Given this list of marker genes SKIDA1, CLDN10, ZDHHC5, LUC7L3, OPTC, DGKH, RERE, KCNC1, ITGBL1, DTX2, LEAP2, ANP32D, LEMD1, DSG1, LAMTOR3, KCNK3, H2AZ1, PDZD2, IKZF4, KRT20, CCM2L, LOX, CDKN1B, PDHA2, EPHA2, AMY2A, PRKAG1, INTS4P1, HAUS3, CNOT2, KLF3-AS1 (NCBI Gene Id 79667), FRY, TMEM145, LTBP3, CPEB4, ACVR2A, BCL9, JPH1, WNT8B, PDGFRA, DLX1, GRM2, GPM6B, RGN, CCDC33, VGF, FOXA1 (NCBI Gene Id 3169), TSHZ2, GAL3ST3, ZNF436, CACNA2D2, CAMLG, NFIL3, COPB1, RAP2B, TOP6BL, NOTCH1, PGM2L1, RRN3P1, TCN2, QRICH1, BDNF, CEP120, SIAH3, WWP2, FGD4, LRRC57, JMJD1C, PDZD9, TCF12, PPM1J, OTP, NUFIP2, ZBTB9, TNMD, HOXC12, FAM227B, VCPKMT, SNAPC1, SOX5, PAX2, RNF128, RBM47, ZDHHC22, DLG3, JDP2, INTS10, FMO1, ARHGAP44, CDH6, CXCL14, SEMA3A, BHLHE22, LRRTM4, ATXN1, HFE, FGF10 (NCBI Gene Id 2255), TSSK3, OBSCN, SMC6, GRIN2B, NEK9, CNTF, TRIM55 (tripartite motif containing 55), RGL2, WNT9A, CCL18, IL1A, PRRX1, MCC, WNT2, SCNN1A (NCBI Gene Id 6337), ADAMTSL1, HEPACAM (hepatic and glial cell adhesion molecule), PRDX6, PHYKPL, CD24, ELMO1, ADCY3, PAX3, SYP, GRIA3, CNTN4, SCD, PPP2R3A, FITM1, SERPINB12, PACS1, SMPX, NNAT, GRAP, WNT3, ZNF436-AS1, C10orf53, PLPPR1, NECAB3, TAFA1, PRG2, SHH, CA5B, BMP10, RGS3, PIGV (phosphatidylinositol glycan anchor biosynthesis class V), ZNF688, MXI1, SSH2, RAB39A, C2CD2L, BACE2, SSUH2, RCN1, ZEB2, SLC15A2, SND1, TYRO3, TSGA10, HEPACAM2, DTNA (NCBI Gene Id 86552), CXCR4, GEN1, IL23A, KCNIP1, PON2, COLCA1, HIVEP1, HMGN2, CCN2, OR2L13, LRRC74A, DLX2, LBX1, FILIP1, C22orf31, HOXA5, LRP5, CCAR2, GRM3, STIM1, UVRAG, SPEM1 (NCBI Gene Id 374768), FOXC1, CACNA1G, TASOR, KLK15, PDZRN4, PALLD, RUNX1T1, CPNE1 (NCBI Gene Id 8904), NUTF2, CACNB3, PANK1, CAPN6, HAPLN2, POLD4, TMEM185A, PPP1R10, BMPR2, SCML1, KCNB2, AHSG, RWDD1, CTDSPL, USP54, GABRA1, KLF10, HMGCS1, IL1RAPL1, CD96, TMEM216, ZNRF2, ELOVL6, RAB30, MRPS18B, MT2A, CHST9, RBMS3, TNNI1, FBLIM1, ATOH7 (atonal bHLH transcription factor 7), TMEM204 (transmembrane protein 204), TAGAP, NR4A3, BRD4, LINC00670, SH3BP4, UTP18, IRX4, KCNJ1, SCUBE3, SLC38A6, SESN3, OTX1, HTN1, DCHS2, RHEBL1, RAB3C, PAN2, FAM120A, KLF3, ICE2, SIT1, PICALM (NCBI Gene Id 8301), BEND4, ANO3, EYA2, UBE3A, ESRRA, NCDN, MAP4K5, PDE4D, ITGAL, SLC32A1, HOXB8, GPM6A, PDC, SSBP2, RAB1B, SRGAP1, MRPL14, NEXN, PPP2R2A (NCBI Gene Id 5520), TMEM164, CDC42EP4, GIPC2 (NCBI Gene Id 54810), NR2F1, FCHSD2, ONECUT1, SEPTIN7, SIX4, here is a description of the gene set: Genes having at least one occurrence of the motif NWNAGRACAN in the regions spanning 4 kb centered on their transcription starting sites. This matches the NR3C1 transcription factor binding site V$PR_Q2 (v7.4 TRANSFAC). Human Gene Set: PR_Q2 studied in species Homo sapiens